Given this list of marker genes DSP, RERE, BHLHA9, JUP, HOXD13, here is a description of the gene set: Human Gene Set: HP_3_4_FINGER_OSSEUS_SYNDACTYLY species: Homo sapiens Fusion of the third (middle) and fourth (ring) finger, involving soft parts and including fusion of individual finger bones. 3-4 finger osseus syndactyly